Given this list of marker genes MAPK1, KRAS, HRAS, SOS2, RAF1, SOS1, GRB2, NRAS, ARAF, MAP2K1, MAPK3, ABL1, BRAF, MAP2K2, here is a description of the gene set: Human Gene Set: KEGG_MEDICUS_VARIANT_BCR_ABL_FUSION_KINASE_TO_RAS_ERK_SIGNALING_PATHWAY studied in species Homo sapiens BCR-ABL fusion kinase to RAS-ERK signaling pathway. Pathway ID: N00002. Pathway type: Variant. Pathway class: nt06276 Chronic myeloid leukemia. Pathway Definition from KEGG: BCR-ABL -> GRB2 -> SOS -> RAS -> RAF -> MEK -> ERK